The following is a description of a gene set: studied in species Homo sapiens A localization process that acts on a protein complex; the complex is transported to, or maintained in, a specific location. Human Gene Set: GOBP_PROTEIN_CONTAINING_COMPLEX_LOCALIZATION, and this is the list of marker genes: EXOC3, IFT52, VAC14, SUSD4, VWC2, CBLB, MAK, RAPSN, KIF2C, SDAD1, PML, RAB4A, RPS15, LSG1, DYNC2H1, EZR, TAMALIN, NOP9, NME7, KIF5B, IGHE, KIF17, SEH1L, NSG1, RPGR, EPB41L3, RCC2, TRAF3IP1, DRD4, AP2B1, IFT140, CPLX1, FXR1, CACNA2D2, IFT80, DAG1, CACNG2, LPAR1, MDN1, ATR, LMNA, MZT1, RELN, ERBB2, AP3M1, KIFC2, ARL3, LMNB2, RIOK2, ITGB3, USP6, VPS26B, NCDN, RABL2B, HPCA, GPC4, IFT25, FUZ, NLGN1, SSNA1, GABARAP, ATAD1, BIRC5 (NCBI Gene Id 332), NMD3, RAB7A, FKBP4, IFT57, CCDC38, SMAD7, AP2M1, AP2S1, CEP112, CNIH3, ADAM10, GPC6 (glypican 6), TSPAN9, HIP1, SGCD, DYNC2I1, TERF1, IFT70B, DLG1, GRIP1, EPS15, RNF220, CACNG5, TMEM232, TYROBP, PCM1, RDX, LCA5, DYNC2LI1, IFT22, GRIP2, EXOC3L1, TTC21A, NUP88, SSX2IP, CEP131, AP2A1 (adaptor related protein complex 2 subunit alpha 1), WDPCP (NCBI Gene Id 51057), DLG4, LTV1, TMEM108, RALB, SCRIB, KLHL21, NRXN1, EIF6, NPTX1, DBN1, CEP72, TRAF6, NRG1, IFT20, INTU (inturned planar cell polarity protein), AP2A2, CACNG3, IPO9, NPM1, ZDHHC3, NACC2 (NCBI Gene Id 138151), RAB8A, EXOC3L4, DYNC2I2, AKAP9, CACNG4, IFT56, STX3, AP3D1, NETO1, WDR35, AKIRIN2, IFT46, NDC1, CLUAP1, DYNLT2B, ZDHHC2, DLG2, BBS12, SACM1L, NPTN, WDR19, CACNG7, SNAPIN, SPAG17, CILK1, CALY, GHSR, MKLN1, LCA5L, KIFAP3, EPG5, HRAS, GRIPAP1, LMNB1, MDM2, RALGAPA2, RAN, CACNG8, GPHN, RAB11A, FCMR, IFT43, FCER2, RBM10, IFT27, ARC (NCBI Gene Id 53837), SLC12A5, IFT74, MAP2K1, NUMB, WASHC5 (WASH complex subunit 5), VPS35, ERBB4 (erb-b2 receptor tyrosine kinase 4), LRRC7, NETO2, IFT88, WASL, RALA, ARHGAP44, IFT172, OPHN1, ZNF365, XPO1, VAMP4, RABEP1, TUB (NCBI Gene Id 7275), RAP1A, KIF5C, TNFAIP2, SYT17, PPP3R1, LHFPL4, GSG1L, KIF5A, GPSM2, STX7, DLG3, IFT70A, GIT1, OGT, CLSTN1, EFNB2, USP46, ATM, MIOS, SLC1A1, IFT122, DZIP1, OLFM1, IQSEC2 (NCBI Gene Id 4382), LGI1, SHISA6, DYNLL1, C1QL2, IFT81, KIF3B, DAW1, C1QL3, TTC21B